The following is a description of a gene set: The binding of an endothelial cell to the extracellular matrix via adhesion molecules. Mouse Gene Set: GOBP_ENDOTHELIAL_CELL_MATRIX_ADHESION species: Mus musculus, and this is the list of marker genes: Rin2, Rras, Fut1, Sec1, Adamts9, Plpp3, Mmp12, Gfus, Pecam1, Dicer1